Given this list of marker genes Parn, Gar1, Tent4b, Dhx36, Smg5, Tep1, Smg7, Wrap53, Pinx1, Snrpb, Hnrnpc, Exosc10, Nhp2, Snrpd3, Naf1 (NCBI Gene Id 277960), Dcp2, Tert, Nop10, Xrn1, Hnrnpu, Smg6, Dkc1, here is a description of the gene set: Mouse Gene Set: GOMF_TELOMERASE_RNA_BINDING studied in species Mus musculus Binding to the telomerase RNA template.